Given this list of marker genes ABCA1, OSBPL1A, GRAMD1C, OSBPL9, SCP2, APOA1, OSBP, STARD5, STARD4 (NCBI Gene Id 154899), OSBPL2, PLTP, CETP, ABCG5, STAR, OSBPL7, APOA5, MTTP, GRAMD1B, APOA2, STARD3, ARV1, OSBPL3, NPC1, OSBPL6, ABCG8, GRAMD1A, APOE, TSPO, APOA4, ABCG1, NPC2, APOB, here is a description of the gene set: species: Homo sapiens Human Gene Set: GOMF_STEROL_TRANSFER_ACTIVITY Removes a sterol from a membrane or a monolayer lipid particle, transports it through the aqueous phase while protected in a hydrophobic pocket, and brings it to an acceptor membrane or lipid particle.